The following is a description of a gene set: from publication Manel N, Hogstad B, Wang Y, Levy DE, Unutmaz D, Littman DR (PMID 20829794) Dendritic cells (DC) serve a key function in host defense, linking innate detection of microbes to the activation of pathogen-specific adaptive immune responses. Whether there is cell-intrinsic recognition of HIV-1 by host innate pattern-recognition receptors and subsequent coupling to antiviral T cell responses is not yet known. DC are largely resistant to infection with HIV-1, but facilitate infection of co-cultured T-helper cells through a process of trans-enhancement. We show here that, when DC resistance to infection is circumvented, HIV-1 induces DC maturation, an antiviral type I interferon response and activation of T cells. This innate response is dependent on the interaction of newly-synthesized HIV-1 capsid (CA) with cellular cyclophilin A (CypA) and the subsequent activation of the transcription factor IRF3. Because the peptidyl-prolyl isomerase CypA also interacts with CA to promote HIV-1 infectivity, our results suggest that CA conformation has evolved under opposing selective pressures for infectivity versus furtiveness. Thus, a cell intrinsic sensor for HIV-1 exists in DC and mediates an antiviral immune response, but it is not typically engaged due to absence of DC infection. The virulence of HIV-1 may be related to evasion of this response, whose manipulation may be necessary to generate an effective HIV-1 vaccine. species: Homo sapiens Human Gene Set: GSE22589_SIV_VS_HIV_AND_SIV_INFECTED_DC_DN Genes down-regulated in monocyte-derived dendritic cells infected by: SIV versus HIV and SIV., and this is the list of marker genes: SMAD5, FOXN1, LRRC3, SLC35F6, REPIN1, CBS, FBXL14, ZNF605, UFSP1, MSX1, BRINP3, RHOF, TAFA1, CFHR2, SLC38A3, SCN8A, UBR2, MEP1A, KBTBD7, NUBP2, BRDT, UROC1, GNAS, FZD10, TPM2, TRIM40, PRR3, CCDC110, MARK1, ALOX12B, MYO10, DSE, SLC12A2, TEK (TEK receptor tyrosine kinase), CUL9, ARHGEF37, DNAH17, SLURP1, CHD4, IRF2BP2, UNC45A, RAD21, NR2E3, ZNF784, PKIA, HIP1, IER3IP1, DHCR24, MED15, TNP1, ZBTB24, UNC50, RPLP2, LMOD2, DSTYK, CORO6, MXD3, CRABP2, RPAP2, FAM217A, PAQR3, BAHD1, RDH13, TNFRSF19 (TNF receptor superfamily member 19), LUZP2, MRAP2, CRYGD, TEX47, CLDN14, ZNF706, DUT, CDRT4, EME2, MITD1, ADGRG1, GNPTG, TXLNB, GLB1L, PDZD11, SLC6A14, SLC27A2, RGS10, SH3D21, BTG3, DNAJC27, CBLN1, USF2, MTERF2 (NCBI Gene Id 80298), KCNQ3, STARD7, DUSP8, ATF7IP, CYP2S1, DIPK2B, DDC, KLF1, STMN3, KANK2, CYB561A3, ZNF569, ACTL9 (actin like 9), KIF17, KRT81, DRC3, PHLPP2, FAM135B, TMEM104, PTBP1, DOLK, SEPTIN9, KCNA1, BARHL2, KRTAP19-5, PRR9, RNF128, TMEM50B, CSF3, PROM2, PDIA2, SLC6A1, MRI1, DIXDC1, GORASP2, OLFM1, DLL4, PNMA2, SNAP23, LYPLA2, PADI6, TEX22, SLC36A1, BRWD1, ZNRF3, ZDHHC9, FANCF, TCEA3, GZF1 (GDNF inducible zinc finger protein 1), CCDC120, RASGRF1, DRD2, PPP6R2, SLC43A2, B4GALT5, DDX20, NBEA, TXN, UQCRC1, AGL, THOP1, KRT36, HERC3, UMAD1, KCNF1, NLRP12, NCOA3, BHLHE41 (NCBI Gene Id 79365), PTPDC1, LRIT2 (leucine rich repeat, Ig-like and transmembrane domains 2), CEBPA, GPR19, PPP1R18, PTPN13, SYCP3, NLRP4, CHERP, AGO2, NPR1, AMZ1, NFXL1, YPEL4, MPPED2, IL17RB, KRT28, APOF, HBB, MUSTN1, SRP14, TANGO6, SIPA1, MSC, JUP, WNT16, TSPAN6, ROGDI, DNAJB12, DNAAF5, H19, RWDD4, BEND3, ATP6V0E2, SLU7, TIMM17B, PRSS44P, CYB561, CENPL, B3GAT3 (beta-1,3-glucuronyltransferase 3), LYZL6, PPP2R2D, ZXDB, PTPN9